The following is a description of a gene set: Genes predicted to be targets of miRBase v22 microRNA hsa-miR-6071 in miRDB v6.0 with MirTarget v4 prediction scores > 80 (high confidence targets). species: Homo sapiens from publication Chen Y, Wang X (PMID 31504780) Human Gene Set: MIR6071, and this is the list of marker genes: PTPN2, SORBS2, YAP1, RALBP1, STAG2, ZNF395, PTP4A2, KPNA4, RPS6KA1, ARHGAP42, FST, SPRING1, NFASC, ARFIP1, UGT3A1, SLC5A3, PHLDB1, TYSND1, VGLL3, FHL1, TOM1L1, C8orf44-SGK3, DLG3, TMEM150A, BANK1, HRNR, SPX, IHO1, ZPR1, TRPS1, TLE1, STAM2, IFNK, TBL1XR1, CLN5, MTCL2, GKAP1, MBNL3, MAN1C1, TUT4, MAP3K20, SLAIN2, DCX, UBL3, MXI1, PLCXD2, PDS5A, FBXO22, JRK, KLRD1, SOX6, PCGF6, LDLRAD4, SLC25A15, STEAP2, BTRC, TRABD2B, TLCD4-RWDD3, SH3D19, DLGAP1, USP3, TFDP1, CCDC40, YPEL2, PACSIN2, FAM149B1, RHPN1, IKZF2, IRS1 (insulin receptor substrate 1), KLHL2, PAXBP1, MIP, KIAA1549L, CLDN8, CREG2, CYFIP2, SERF2, CDC42BPB, CEBPZOS, RAD23B, CNOT10, OSBPL2, SPINK5, RCC1, ARF4, EGFLAM, LDLR, ESM1, ZIC2 (Zic family member 2, NCBI Gene Id 7546), POLH, GATAD2A, FAM53C, CACNA2D4, ADNP, WNT3 (Wnt family member 3), CRACR2B, PEX11B, SAP30L, GANC, DCAF8, KIAA1958, MBP, LGALSL, CDKN1B, KCNG1, NR6A1, AICDA, GFRA1, TBXT, NEUROD1 (neuronal differentiation 1), XYLB, DNAJC27 (DnaJ heat shock protein family (Hsp40) member C27), OGT, DPF3, PLPPR4, KCNH5, SMDT1, NLGN3, DCP1A, MORN4, BCL2L11, EFHC2, FUT2, NNAT, ARMH4, PAX9, ZNF793, FSTL5, NFATC3, GREM2, SIK2, RAB30, TENT5A, FCHO2, PNN, UBR3, HECTD2, RBBP6, NAPB, CWC27, RASSF8, EDN1, RAB3B, CLEC4F, FZD3, TOR1AIP2, ZRANB1, SNX27, EMB, UBE2D3, MAB21L2, TFB2M, ERC1, SLC46A3, CASK, PRPS1, ZNF704 (zinc finger protein 704), RNF24, ZBTB20, MFSD14B, TPST1, DDI2, MAPK8, DUOXA1, TMPPE, AMD1, DYRK1A, TRERF1, RAB39A, EBF3 (NCBI Gene Id 276717), PKIG, SET, C1QL2, ZNF695, FOXO3, PDGFRB, SGK3, SNX18, KAT6A, PHF5A